The following is a description of a gene set: Genes predicted to be targets of miRBase v22 microRNA hsa-miR-3662 in miRDB v6.0 with MirTarget v4 prediction scores > 80 (high confidence targets). Human Gene Set: MIR3662 species: Homo sapiens from publication Chen Y, Wang X (PMID 31504780), and this is the list of marker genes: ELAPOR2, PCDH7, SAR1B, SLC44A1, DCK, PIGK, PLXNC1, FBN2, ANKRD13C, CFHR2, RASSF8, STAM, PIK3C2G, HIPK3, UBR1, FAM117B, GABRB2, IPMK, FAR1, TIAM2, GTF2E1 (NCBI Gene Id 2960), DGKH, FGF7, LHX8, TAOK1, SAMD8, EFCAB7, KRTAP9-3, IFIT1, SEPHS1, TMX4, ZNF84, EIF1AX, TMEM33, NIN, ROR2, UBE2D1, TNFRSF11B, XK, TP53INP1, ZNF326, SLC35G1, PTPRS, SOX21, POLH, BRWD1, PPM1B, JCAD, LCORL, MLLT3, BACH2, UBE2Q2, TEDDM1, INTS6L, AKAP13, PCSK2, SGIP1, C4orf3, FAM218A, CAMTA1, SNRNP40, CBL, UGT1A10, ARHGAP42, BAAT, NR2F1, RLIM, RAB3C, UTRN, CEP68, SEZ6L, RNF2, JAKMIP2, PPP2CB, MMRN1, OR51E1, PLXDC2, NUFIP2, KPNA1, GOLGA8R, PAFAH1B1, PRKCE, MMP16, ZNF236, EBF3, METAP1, MAPK6, MAST4, ASPH, ZIC3, SLC30A4, PTGDR, ARID4A, ARHGAP20, CCDC88A, UCKL1, RTKN2, RBMS3, HAPSTR1, HOOK3, NSD2, HECW2, PAK4, LINC02693, TCFL5 (NCBI Gene Id 10732), ATAD2B, KLRC1, NOVA1, LETM2, ELMOD2, SLC5A12, SF3A1, ENDOD1, PCMTD1, BCAT1, DENND1B, MBLAC2, XG, ENPP5, PDE4D, VPS36, ZNF507, SCML2, TMEFF1, SSPN, KLHL4, AMOT, PHF6, PRKG2, LOX, DHX35, RANBP3L, ALG10B, FSBP, PKIA, RC3H1, SMAP1, SH3TC2, FREM1, OGFRL1, PSMC2 (NCBI Gene Id 5701), MAP4K3, PLK4, PTPRF, SNX13, RALGPS1, IGF2R, PGK2, SRBD1, SAMD4B, BCL11A, IMPACT, AMMECR1, ACVR1C, BCL2L15, CEP170, TCF20, ATE1, GUF1, CMKLR2, ZNF619, DLG5, ZPLD1, MAP3K1, SPDYE1, GABRP (gamma-aminobutyric acid type A receptor subunit pi), ACSL4, PIK3R1, ST8SIA6, LPCAT1, PIGN, SEC62, SEC22C, BMPR2, HS6ST2, GEM, ZBTB10, C5AR2, PABPC5, C2CD4A, SLC25A46, TRIM36, RORA, GADL1, DYNC1I2, CILK1 (NCBI Gene Id 51541), CERT1, RUNDC3B, EPHA5, TIGAR, CREB1, SCAI, UGT8, KMT5B, HDAC9, ZNF148, PGAP1, ASB5, UBE4A (NCBI Gene Id 9354), PHYHIPL, CDC42EP3, OXCT1, SORT1, PRR16, WNT5A, MBTD1, GABRG1, CCN2, MBTPS2, SCYL2, TLCD4, CELF2, ERBIN, ABCD2, NLN, FUBP3, NRXN1, XRN1, APPL1, FRK, SLC30A7, ATP11C, GRID1, PSD3, SREK1, UGT1A9 (UDP glucuronosyltransferase family 1 member A9), YIPF6, FLT1, ZIC4, TPCN1, TMEM47, MEF2C, ANKLE2, FER, ATP8B2, CACNB4, ZBTB2, CCDC170, PLEKHA1 (pleckstrin homology domain containing A1), CALCRL, MXD1, PERP, ABHD18, PHKA1, MAP2K1, DNAJC9, NR2C2, MDN1, CXCL14, NHS, ZKSCAN8, CENPK, ABCA12, ACADSB, DYNC1LI2, PPP3CA, ELOVL5, IGDCC4, MYOZ2, RHBDD1, DNAJC18, MIER1, PTPN4, GNB4, COL19A1, B3GALNT2, ERBB4, RP1, TMEM245, CPSF6, ZNF608, CLOCK, CNOT6L, LMO3, C1orf141, CPE, PRLR, TMTC3, CEP43, PCDH19, RAB18, RB1CC1, UGT1A3, PATZ1, GNA13, SPON1, ZBTB20 (zinc finger and BTB domain containing 20), DOCK7, TFDP1, NFAT5, SRP72, AFF2, YME1L1, PAG1, CDK13, ARK2N, IKZF2, PPM1L, MOB1B, MLLT11, FGA, ZBTB44, POU3F2, MSR1, ZFHX4, SETD7, SPDYE3, ZC4H2, STOX2, ANKRD27, ASXL1, HDX, GABRA4, GRIA4 (NCBI Gene Id 2893), ZSCAN9, TLX1, RO60, PCDH20, DDHD1, MAPK8, RSBN1L, FAT4, BTBD7, STARD4, RAG1, BRWD3, KAT6A, LIMA1, FBXO38, ZFX, WDR20, UGT1A5, ZNF800, ACTL6A, PKD2, PPM1K, TENM1, TSHZ2, ARFGEF3, TOR1AIP2, RAB27B, PRPF39, PAK2, CAB39L, PAX6, LGR4, SLC1A2, CPEB3, PGR, SRGAP1 (NCBI Gene Id 57522), PDE1C (NCBI Gene Id 5137), PCP4L1, CYP4A22, RNF144B, STAG2, GNPDA2, REEP3, GOLGA8H, NRG2, DNAL1, NFYB, ZFAND6, ID4, MAN1A2, SAXO2, KLHL42, PDE10A, IPO8, DPP4, ALDH5A1, KL, FARP1, YY2, FGF5, SERPINB13, PCDHB16, SEMA3A, ZNF420, ADD3, OSR2, INO80D, CTSV, MTX3, RICTOR, HS3ST3A1, HMCN1, EDEM3, GTF2H5, ARHGAP12, CEP85L, ADAMDEC1, EPHA3, SMIM13, NAA30, WDR26, LTBP1, CDK17, RP2, LYSMD3, ANGPTL1, HDAC1 (histone deacetylase 1), FBXO42, LGSN, SRSF1, CLVS1, ACER3, LSM14A, DMAC2L, SELENOI, RADX, CDC42BPA, KBTBD8, FLNB, PCNP, EIF4E, PTPRJ, NRP1, SOCS4, MAP3K8, GXYLT1, NFIB, ESCO2, CREB5, MTCL3, TMF1, GAS2L3, PTAR1, SDHC, TBC1D32, MID1, UNC13C, TRIM33, INSYN2A (inhibitory synaptic factor 2A), LRRFIP1, SLC39A10, RFT1, NDN (NCBI Gene Id 4692), NAV1, ODF2, SMARCAD1, NEK7, USP15, STAU1, PKNOX1, BAZ2B, GRIN3A, KANK2 (KN motif and ankyrin repeat domains 2), HNF4G, UBE2E2, IL22, ARHGAP28, UGT1A6 (NCBI Gene Id 54578), POTEE, OSBPL11, GALNT13, BCO1, GPM6A, RAP2B (NCBI Gene Id 5912), PRKAA1, PNISR, SBNO1, CAMK4, ACTR2, RNF169, NAA25, CDC6, GPR18, ATG10 (autophagy related 10), FGF12, CADM2, GSK3B, FERMT2, RUFY2, EPC2, RETREG2, C1orf131, PCDH15, SRSF10 (serine and arginine rich splicing factor 10, NCBI Gene Id 89048), RNGTT, KCNV1, CPNE3, QSER1, HNRNPU, CSTF2, FLRT2, OLFM3, PLCL1, PDS5B, PPIL4, SUPT4H1, HDAC2, SEPTIN10, LGALS8, SPOCK3, CYBB, HEATR5A, RAD1, GPATCH2L, CNTD1, TRIM25, NMNAT1 (NCBI Gene Id 64802), HNRNPF, TBC1D12, VKORC1L1, TRIM23, NETO1, FZD4, TAB3, OSBPL1A, ETNK1 (ethanolamine kinase 1), SLC8A1, SSB, MTMR6, PTPRD, SCN3A, B3GALT2, CREBRF, RFX7, SP3, NDUFA5, SLC44A5, MBNL3, PHEX, PDE8A, FZD3, KLF12, ALG11, SH3D19, HAUS2, EPB41L4B, THAP12, ZC3H12C, LRRC8B, THEMIS2, HNRNPR, RBPJ, RARA, SPTY2D1, CKS1B, NUSAP1, SLC16A7, PRPF40A, EEIG2, USP53, PPP1R12A, THOC2, EPHA7, HFE, THBS1 (NCBI Gene Id 7057), PPM1A, SEH1L, TOX, C12orf50, FGF14, CEP120, FNDC3A, STRN, ADAT2, DCUN1D1, SMURF2, ZEB2, TNPO1, ST13, EIF5A2, FBXW4, RAB28, ZBTB6, SHC4, EOGT, OSBPL3, ENSA, ASB7, ABCG1, SRGAP2, KBTBD11, TSHZ1, ELAVL1 (ELAV like RNA binding protein 1), PPP1R15B, XPR1, SCN1A, TMEM135 (transmembrane protein 135), TMEM241, TMEM144, FKBP1A, RALGAPA1, GDAP2, AAK1 (AP2 associated kinase 1), RNF170, UBE2QL1, RIPOR2, SPTBN1, OSGIN2, CNOT6, CCNC, RNF217, AMPD3, PPP1R3B, C18orf54, R3HDM2, UBE2K, ZBTB1 (NCBI Gene Id 22890), REST, POU1F1, GRIA2, ERLEC1, CNTN1, PRKACB, UBR5 (NCBI Gene Id 51366), GPR63, FRG2C, FAM81A, UBE2D2, SPDYE5, LSAMP, METRNL, SAMSN1, ANKRD22, ZNF649, LRRTM3, IFI44L, MSANTD2, FANCF, SYT14, ZDHHC2, CLDND1, IL1RAP, LHFPL6, GCN1, AFG1L, PALM2AKAP2, ZDHHC3, ZBTB7C, TASOR, GTF2A1, TEAD1, DCAF12, TASOR2, C18orf21, NONO, PLEKHA5, THSD7A, HRH4, AK4 (NCBI Gene Id 387851), CTDSPL2, FAM216B, KLF3, NR2C1, UPP2 (uridine phosphorylase 2), C8A, KCNJ3, SLC6A15, SCN8A, PBRM1, UGT1A8, EYA1, OPRM1, LIFR, CBLL1, CDC14B, PRDM5, CACUL1, PIAS2, RPS6KA6 (NCBI Gene Id 27330), RIMOC1, SCN11A, NUDT4, PIP4P2, ELK3, SHROOM4, UNC80, SLC35D1, UGT1A7 (NCBI Gene Id 54577, UDP glucuronosyltransferase family 1 member A7), OTP, FMR1, MYEF2, CAB39, SNTG1 (syntrophin gamma 1), PTPRB, TFEC, SP8, SVIL, APPBP2, MSTN, DHX57, ARHGEF12, SH2D4B, ARHGAP29, LZTFL1, CFLAR, ADGRG2, BMX, APOLD1, FBLN2, ERLIN1, PHF21A, ZNF264, ADNP, CA8, ANKRD12, UTY, LRRN3, TMEM59, SIX4, HEXIM1, DCAF8L1, PLEKHH2, SOX6, ANKRD42 (ankyrin repeat domain 42, NCBI Gene Id 732033), ERRFI1, GPR34, PLEKHM3, TNFRSF9, DICER1, RBM22, EVI5, NR2F2 (nuclear receptor subfamily 2 group F member 2), RBM7, PABPN1L, GOLM2, DPYS, RTF1, CREBZF, CAMSAP2, CCL16, LIN7A, FBXO43, BPNT2, CLMN, FGD6, ROBO1, DISC1, TRIM6, TMPRSS11B, LIN7C, CDH11, NAB1, LCLAT1 (NCBI Gene Id 253558), PRKAA2 (protein kinase AMP-activated catalytic subunit alpha 2), MFAP3L, COPG2, EEF1E1, PHF3, PPP6R3, PLAG1, SNAP29, VWA8, YAP1 (Yes1 associated transcriptional regulator), UGT1A1, XIAP, ADAM22, RUNX1T1, ENPEP, TBCB, EXPH5, RCOR3, FGG, SFPQ, FKTN, PDSS1, CXXC4, NID1, CGGBP1, EEF2K, PEAK1 (NCBI Gene Id 79834), INTS6, EFNA5, ZNF268, ELK4, ANKRD28, RBFOX1, YIPF5, TRAK2, CXADR, DERL1, CBLIF, ZNF385B, LRRC8C, CERS6 (NCBI Gene Id 253782), BIVM, TNRC6B, RDX, FAM133B, SYNCRIP, SEL1L, ANO6, NPR3, FRG2, BVES, ZNF273, PLCB1, RAP2C, SIKE1, GOLGA8M, STRIP2, TAFA2, C5orf24, APP, TTLL7, IGF1, KCNK13, C18orf63, EDIL3, TMEM182, CCDC47, MKX, VPS13A, EFR3A, GOLGA8J, PDE6C, TRIM9, CTTNBP2NL, SASS6, ASXL3, SLC7A11, IKZF5 (NCBI Gene Id 64376), ZNF260, SEPTIN11, GABPA, PHACTR2, MAP3K2, CTAGE1, CBFB, DCC, VSIG1, STXBP5 (syntaxin binding protein 5), SYT1, RAP1A, UBE2J2, RSKR, ERLIN2, MTNAP1, C1GALT1 (core 1 synthase, glycoprotein-N-acetylgalactosamine 3-beta-galactosyltransferase 1), SRSF2, TRPC3, SLC2A10, SOX30, MED1, HHIP, GTPBP10, FAM199X, PRTG, KDM7A, MAP4K5, CNR1, PDE12, SMARCA2, SYNPO2, MAGEA8, KALRN, NDFIP2, NXPE3, HGF, GAN, MARK1, BOD1L1, LRP12, STAG1, OBI1, PPP1CC, MTF2, MAPRE2, EPM2AIP1, LIN54, TRAF3, KRT40, F2R, PSMA8, ATRX, TBK1, KIAA0408, MTHFD2, IL1A, PBX1, PAQR3, ORC4, HIPK1, MGAT2, MGST3, UGT1A4, TIMM21, C21orf91 (chromosome 21 open reading frame 91), GPM6B, C2orf15, PTPN2, HP1BP3, DNAJB14, KPNA4, FAM168A, TENM3, NKRF, EMSY, ARHGAP5, HSPH1, TRPS1, FEM1C, REPS2, ZC3H8, PTPN22, ZNF197, GULP1, NCAM2, TOMM20, ZBTB24, TCP1, ZNF510, GOPC, PAPOLA, RAB21, FOXO1, STT3B, VAPB, ZEB1, TRIM22, WWTR1, PCGF6, SIPA1L1, GOLGA8Q (golgin A8 family member Q), SLC9C2 (solute carrier family 9 member C2 (putative)), ZNF451, ZNF737, SGCB, SLC35F1, LDLRAD4, MFF, PRRG1, MGAT4A, MEIS2, AGFG1, SSH2 (NCBI Gene Id 85464), GOLGA8T, CNTN3, TRPM1, FAXC, GOLGA8N, GUCY1A1, SPCS3, NAA16, MANEA, USP44, TENT4B, SPDYE6, KCNT2, EXOC5, ARL15, CTCF, HS3ST5, MRPL30, HDGFL3, HUS1, ANKH, PTGR3, ZMAT3, KLRC2, PRKG1 (protein kinase cGMP-dependent 1), HTR2C, NAGS, PREPL, IRGQ, HECA, PHF20, CUX1, VSX1, TCF7L2, HYCC2, GPC6, ZNF227